The following is a description of a gene set: from publication Ludwiczek S, Theurl I, Muckenthaler MU, Jakab M, Mair SM, Theurl M, Kiss J, Paulmichl M, Hentze MW, Ritter M, Weiss G (PMID 17293870) Human Gene Set: LUDWICZEK_TREATING_IRON_OVERLOAD Hereditary hemochromatosis and transfusional iron overload are frequent clinical conditions associated with progressive iron accumulation in parenchymal tissues, leading to eventual organ failure. We have discovered a new mechanism to reverse iron overload-pharmacological modulation of the divalent metal transporter-1 (DMT-1). DMT-1 mediates intracellular iron transport during the transferrin cycle and apical iron absorption in the duodenum. Its additional functions in iron handling in the kidney and liver are less well understood. We show that the L-type calcium channel blocker nifedipine increases DMT-1-mediated cellular iron transport 10- to 100-fold at concentrations between 1 and 100 microM. Mechanistically, nifedipine causes this effect by prolonging the iron-transporting activity of DMT-1. We show that nifedipine mobilizes iron from the liver of mice with primary and secondary iron overload and enhances urinary iron excretion. Modulation of DMT-1 function by L-type calcium channel blockers emerges as a new pharmacological therapy for the treatment of iron overload disorders. species: Mus musculus Genes changed in liver in response to nifedipine treatment of iron overload., and this is the list of marker genes: LCN2, SLC40A1, TFRC, HAMP, HPX, MT1X, CP